Given this list of marker genes Dpysl5, Atp9a, Tmem138, Clock, Hook3, Kitl, Pramel22, Hycc1, Vldlr, Pramel27, AI597479, Ube2v2, Tmem109 (NCBI Gene Id 98142), Ddx31, Serpinb11, Tmem165, Jarid2, Nos1ap, Zfp30, Dnajb11, Apc, Naa30, Cep112, Prrc2c, Defb29, Slc35a3, Susd6, Rtf1, Creb1, Pcyt1a, Qki (quaking, KH domain containing RNA binding), Cdc25a, Lepr, Rtl4, Polr2c, Poglut1, Nr4a3, Lrp8, Igf2r, Washc4, Ncf1, Zfp772, Zfp148, Fam151b, Spo11, Mlx, Alg2, Sub1, Srrm1, Maea, Plppr1, Fndc9, Elovl5, Morc2a (NCBI Gene Id 74522), Strn, Setd7, Eif3a (eukaryotic translation initiation factor 3, subunit A), Asph, Pja2, Cdk1, Cul3, Hdgfl3, Kdm3b, Fat3, Zfp207, Saysd1, Dsg1b, Cdyl2, 2510009E07Rik, Vtcn1, Raly, Ccpg1, Rprd2, Dnajc19, Hip1, Hnf4g, Serpina7, Zfp60, Xiap, Eya4, Ptbp3, Zmat4, Btbd10, Thrb, here is a description of the gene set: from publication Chen Y, Wang X (PMID 31504780) Mouse Gene Set: MIR_6997_3P studied in species Mus musculus Genes predicted to be targets of miRBase v22 microRNA mmu_miR_6997_3p in miRDB v6.0 with MirTarget v4 prediction scores > 80 (high confidence targets).